Given this list of marker genes SEMA4B, DUSP5-DT, DUSP5, SNORA57, CSKMT, SNORD12C, TATDN3, ILF2 (interleukin enhancer binding factor 2), RNVU1-14, H2BC18, RHOB, C12orf57, RNU7-1, C11orf98, PKM, HOOK2, ABCA7 (NCBI Gene Id 82843), ZNFX1, H2BC5, MALAT1, TM4SF1-AS1, NR4A1, MAT2A, MIR4530, ACTG1, ACTB, EEF1A1, ZFAS1, SCRIB, LINC02709, RPL36AP44, SFN, DVL2 (NCBI Gene Id 1856), JUNB, RNVU1-27, VMP1, here is a description of the gene set: from publication Yevshin I, Sharipov R, Kolmykov S, Kondrakhin Y, Kolpakov F (PMID 30445619) species: Homo sapiens Genes containing one or more binding sites for (EGFR) in their promoter regions (TSS -1000,+100 bp) as identified by GTRD version 20.06 ChIP-seq harmonization. Human Gene Set: EGFR_TARGET_GENES